The following is a description of a gene set: This event has been computationally inferred from an event that has been demonstrated in another species.<p>The inference is based on the homology mapping from PANTHER. Briefly, reactions for which all involved PhysicalEntities (in input, output and catalyst) have a mapped orthologue/paralogue (for complexes at least 75% of components must have a mapping) are inferred to the other species. part of: SUMO E3 ligases SUMOylate target proteins electronically inferred by orthology from the curated human pathway species: Mus musculus Reactome Pathway: SUMOylation of DNA methylation proteins, and this is the list of marker genes: Dnmt1, Dnmt3b, Sumo1